Given this list of marker genes LINC00511, CDH19, NFIB, TNFRSF19, S1PR2, TBC1D16 (TBC1 domain family member 16), USP6NL, NHSL1, ADGRG6, OSBPL10, FGD4, MIA, LRATD2, WDR82, GAS7, ATP11A (NCBI Gene Id 84170), OPHN1, ETS1, CHAMP1, CSRP2, DNMT1, H1-9P, ACSS1, ST6GAL1, ERBB3, TTLL4 (tubulin tyrosine ligase like 4), NES, RHOJ (ras homolog family member J), NPAT, here is a description of the gene set: Human Gene Set: PURWIN_A375_MEWO_COMMON_SOX10_TARGETS Genes with a SOX10 ChIP-seq peak in the promoter region that are commonly down-regulated in two A375 and two MeWo CRISPR SOX10 knockout clones. from publication Purwin TJ, Caksa S, Sacan A, Capparelli C, Aplin AE (PMID 37636077) SOX10 is a transcription factor involved with neural crest development and is expressed in cutaneous melanoma. Loss of SOX10 in cutaneous melanoma has been linked to an invasive phenotype as well as resistance to MAPK targeted therapies. Transcriptomic changes due to SOX10 loss was modeled using RNA-seq data from CRISPR knockout in A375 and MeWo melanoma cell lines. Signature genes were generated from the intersect of ChIP-seq target genes and significantly (BHFDR < 0.05) down-regulated genes. studied in species Homo sapiens